The following is a description of a gene set: The BH3-only members act as sentinels that selectively trigger apoptosis in response to developmental cues or stress-signals like DNA damages. Widely expressed mammalian BH3-only proteins are thought to act by binding to and neutralizing their pro-survival counterparts. Activation of BH3-only proteins directly or indirectly results in the activation of proapoptotic BAX and BAK to trigger cell death. Anti-apoptotic BCL-2 or BCL-XL may bind and sequester BH3-only molecules to prevent BAX, BAK activation. The individual BH3-only members are held in check by various mechanisms with in the cells. They are recruited for death duties in response to death cues by diverse activation processes.The mechanisms involved in activation and release of BH3-only proteins for apoptosis will be discussed in this section. <p>The following figure has been reproduced here with the kind permission from the authors. part of: Intrinsic Pathway for Apoptosis Reactome Pathway: Activation of BH3-only proteins species: Homo sapiens, and this is the list of marker genes: BAD, YWHAG, YWHAZ, YWHAQ, DYNLL2, PMAIP1, SFN, DYNLL1, TFDP2, BID, E2F1, AKT1, AKT3, BCL2L11, BBC3, YWHAB, PPP1R13B, TP63, MAPK8, AKT2, YWHAE, PPP3CC, TP73, BMF, TFDP1, YWHAH, BCL2, TP53BP2, PPP3R1, TP53